Given this list of marker genes CEP72, SLC35G2, BHLHE41, CHML, CTHRC1, FAT4, RAPGEF2, TMEM54, XCR1, RCAN2, SNRK, FOXRED2, UIMC1, CCDC32, AMHR2, XPR1, BYSL, CEP104, UBA6, SAV1, KDM1A, VASP, SLC25A40, TMIGD1, NAA20, MNX1, HADH, CELF5, PRRG3, SHQ1, PPM1K (protein phosphatase, Mg2+/Mn2+ dependent 1K), RIOK2, UPF3B, BMI1, RPL37A, CLN6, SLC30A4, NUP54, FNBP1L, MYO1D, DLEU7, TOX3, APLP1, KCTD13, MIR148B, TMEM201, FAM184B, AGPS, EIF3A, PTPRH, NKRF, DLAT, CPNE5, ABO, TRPV3, GGNBP2, PXDN, ANK1, POC5, LTK, PLEKHA5, HORMAD1, CACNG8, PDE1C, ZBTB41, DEPDC5, RNF38, ZFAND5, RELT, MOSPD2, KCNMB1, KRTAP3-3, GLCE, ABR, CDC16, EIF4B, QSER1, DDX6, KLHL24, ABCG8 (NCBI Gene Id 64241), N4BP2, MCM8, RLIM, PTGR3, POLR3B, PVR, S1PR1, CPM, LPIN3, PHLPP1, SPACA1, H6PD, RNF220, MBNL1, FBXW2, STEAP2, CH25H, NFYA, IFI16, NTMT1, BIN3 (NCBI Gene Id 55909), RUNX2, LHX6, TNPO3 (NCBI Gene Id 404679), PYGL, SESN3, LSG1, MIR342, AVL9, ITGA1, KAT2A, MIR186, TMEM229A, CEP70, MIR34A, KCNG1, FMOD, ADGRG2, GHITM, BCAP29, CELF2, PCF11, PCDHB3, FBP2, TMEM236, PPTC7, TAX1BP1, TIMD4, EIPR1, ABITRAM, TGFB1, TIGD2, KDM5A, TMPRSS11BNL, CSMD2, PIAS4, UBAP2L, WDR26, TRPC4, CBFB, SEC61A2, EIF3E, FSHB, GALNT1, RPL28, GRM6, ATL3 (atlastin GTPase 3), TRUB1, RGP1, here is a description of the gene set: species: Homo sapiens IL-10 or IL-6 stimulation of control 129xC57BL/6 murine bone marrow derived macrophages in the presence of LPS. We used microarrays to detail the global programme of gene expression changes in response to IL-6 or IL-10 stimulation in the presence of lipopolysaccharide. BMDMs were isolated from control, IL-6-/-, and IL-10-/- mice on a 129XBL/6 mixed background mice and differentiated in the presence of CSF-1 for 6-7 days. Cells were scraped and plated in 6 well plates at 2x10e6/well. Cells were washed with complete DMEM and rested for 1-2 hr before stimulation with combinations of IL-10 (10 ng/ml), IL-6 (2 ng/ml) or LPS (100 ng/ml) for 45 min or 180 mins. Complete biological replicates were performed. Genes down-regulated in bone marrow-derived macrophages at 180 min of stimulation with IL10 and LPS: wildtype versus IL6 knockout. Human Gene Set: GSE5589_WT_VS_IL6_KO_LPS_AND_IL10_STIM_MACROPHAGE_180MIN_DN from publication El Kasmi KC, Holst J, Coffre M, Mielke L, de Pauw A, Lhocine N, Smith AM, Rutschman R, Kaushal D, Shen Y, Suda T, Donnelly RP, Myers MG Jr, Alexander W, Vignali DA, Watowich SS, Ernst M, Hilton DJ, Murray PJ (PMID 17114459)